The following is a description of a gene set: A series of specific posttranslational modifications to the CAAX box region of CAAX box proteins. CAAX box proteins are eukaryotic proteins that contain a CAAX motif where the C is a cysteine, the two A residues are aliphatic amino acids and the X can be one of several amino acids. The CAAX-box proteins undergo three sequential, enzymatic, post-translational modifications essential to their targeting: First, the proteins are prenylated by one of two prenyltransferases called farnesyltransferase and geranylgeranyltransferase-I. Prenylation results in the covalent attachment of either farnesyl or geranylgeranyl isoprenoid groups to the cysteine in the CAAX box motif. Prenylation is followed by proteolytic removal of the last three amino acids of the protein (AAX). Finally, the newly exposed carboxylate group of the isoprenylcysteine is methylated by an ER-associated prenyl-dependent carboxylmethyltransferase. Mouse Gene Set: GOBP_CAAX_BOX_PROTEIN_MATURATION studied in species Mus musculus, and this is the list of marker genes: Icmt, Rce1, Usp17le, Rap1gds1, Zmpste24